Given this list of marker genes SMAD2, MLXIPL, SMAD3 (SMAD family member 3), SON, EDA, KCNH1, XYLT1, TGFB2, PIGQ, COL12A1, ELN, KIF22, EFEMP2, IARS1, MGP, COL1A1, RIN2, COL5A2, PRMT7, PRDM5, ZNF469, PAX2, B3GALT6, ABL1, INPPL1, AHDC1, TNXB, PLOD1, MICU1, MAN2B1, COL1A2, ATP7A, TGFBR1, SPARC, AEBP1, MTAP, FKBP14, SLC2A10, ATP6V1B2, ADAMTS2, TGFBR2, C1R, KCNN3, COL5A1, MAP3K7, here is a description of the gene set: studied in species Homo sapiens Subjective impression of increased softness upon palpation of the skin. Soft skin Human Gene Set: HP_SOFT_SKIN